The following is a description of a gene set: Neighborhood of RBM8A studied in species Homo sapiens Human Gene Set: GCM_RBM8A Neighborhood of RBM8A RNA binding motif protein 8A in the GCM expression compendium, and this is the list of marker genes: ZNF84, EPC2, ZNF292, PKNOX1, ATG4B, CELF1, SETD5, MED13, APBB3, SPAG9, NCOA5, VASH1, USP19, CSRNP2, GSPT1, DCTN4, MAP6, GSTA4, MTMR3, MED17, DHX40, GSK3B, RBM8A, SYNC, CAND1, PRRC2B, NAB1, UBE3A, VEZF1, BAZ2A, FOXO3, NGRN, CEP170, NSD2, BRPF3, PGRMC2, FBXO30, LINC01278, UBE2N, RPL7L1, ARB2A, EXOC5, PHF2, ZNF384, MFAP3, ASB3, ADO, UBE2E3, KIDINS220, USP9X, POGZ, TAF9B, ZBED1, TIA1, ZNF512, CLEC16A, VPS26B, ISCA1, NUCKS1, NFYA, ZNF286A, CHTOP, C2CD5, DCAF7, PHC1, KMT2A, ZNF529, ZFTA, KAT7, RIMOC1, RAN, NUP133, CRNKL1, DFFA, NCAM1, SLC25A29, IPO9, IPO7, IQCK, RBM4B, SCARB2